The following is a description of a gene set: Repetitive pressing, poking, and/or rubbing in the eyes. Eye poking Human Gene Set: HP_EYE_POKING studied in species Homo sapiens, and this is the list of marker genes: KCNJ13, IFT140, LRAT, LCA5, RDH12, TUBB4B, AIPL1, RNU4-2, PCYT1A, CRX, RPE65, GUCY2D, IQCB1, IMPDH1, GDF6, TULP1, USP45, NMNAT1, RD3, SPATA7, RPGRIP1, CRB1, CEP290